The following is a description of a gene set: studied in species Homo sapiens Human Gene Set: REACTOME_DISEASES_ASSOCIATED_WITH_N_GLYCOSYLATION_OF_PROTEINS Diseases associated with N-glycosylation of proteins, and this is the list of marker genes: ALG2, B4GALT1 (NCBI Gene Id 2683), ALG9 (ALG9 alpha-1,2-mannosyltransferase), RFT1, NEU1, ALG1, GLB1, DPAGT1, ALG8 (ALG8 alpha-1,3-glucosyltransferase), ALG3, MAN1B1, ALG6, ALG12, MGAT2, ALG13, MOGS, CTSA, MPDU1, ALG11, ALG14